The following is a description of a gene set: Human Gene Set: CARRILLOREIXACH_HEPATOBLASTOMA_VS_NORMAL_DN from publication Carrillo-Reixach J, Torrens L, Simon-Coma M, Royo L, Domingo-Sàbat M, Abril-Fornaguera J, Akers N, Sala M, Ragull S, Arnal M, Villalmanzo N, Cairo S, Villanueva A, Kappler R, Garrido M, Guerra L, Sábado C, Guillén G, Mallo M, Piñeyro D, Vázquez-Vitali M, Kuchuk O, Mateos ME, Ramírez G, Santamaría ML, Mozo Y, Soriano A, Grotzer M, Branchereau S, de Andoin NG, López-Ibor B, López-Almaraz R, Salinas JA, Torres B, Hernández F, Uriz JJ, Fabre M, Blanco J, Paris C, Bajčiová V, Laureys G, Masnou H, Clos A, Belendez C, Guettier C, Sumoy L, Planas R, Jordà M, Nonell L, Czauderna P, Morland B, Sia D, Losic B, Buendia MA, Sarrias MR, Llovet JM, Armengol C (PMID 32240714) Genes down-regulated in hepatoblastoma (HB) tumors as compared with non-tumor (NT) adjacent tissue. Background & Aims: Hepatoblastoma (HB) is a rare disease. Nevertheless, it is the predominant pediatric liver cancer, with limited therapeutic options for patients with aggressive tumors. Herein, we aimed to uncover the mechanisms of HB pathobiology and to identify new biomarkers and therapeutic targets in a move towards precision medicine for patients with advanced HB.<br/>Methods: We performed a comprehensive genomic, transcriptomic and epigenomic characterization of 159 clinically annotated samples from 113 patients with HB, using high-throughput technologies.<br/>Results: We discovered a widespread epigenetic footprint of HB that includes hyperediting of the tumor suppressor BLCAP concomitant with a genome-wide dysregulation of RNA editing and the overexpression of mainly non-coding genes of the oncogenic 14q32 DLK1-DIO3 locus. By unsupervised analysis, we identified 2 epigenomic clusters (Epi-CA, Epi-CB) with distinct degrees of DNA hypomethylation and CpG island hypermethylation that are associated with the C1/C2/C2B transcriptomic subtypes. Based on these findings, we defined the first molecular risk stratification of HB (MRS-HB), which encompasses 3 main prognostic categories and improves the current clinical risk stratification approach. The MRS-3 category (28%), defined by strong 14q32 locus expression and Epi-CB methylation features, was characterized by CTNNB1 and NFE2L2 mutations, a progenitor-like phenotype and clinical aggressiveness. Finally, we identified choline kinase alpha as a promising therapeutic target for intermediate and high-risk HBs, as its inhibition in HB cell lines and patient-derived xenografts strongly abrogated tumor growth.<br/>Conclusions: These findings provide a detailed insight into the molecular features of HB and could be used to improve current clinical stratification approaches and to develop treatments for patients with HB. species: Homo sapiens, and this is the list of marker genes: TIFA, CHP1, CMYA5, FNDC5, REPS2, ADCY10, ACOT13, VIPR1, FGF14-AS2, CNDP1, LSMEM1, CLEC4G, ISOC1, NFKBIB, NLRP9P1, NFIA, AQP7P1, CA2, ENO1P3, NUDT13, MT1JP, ARAP2, SDHD, MAP1LC3A, ID1 (NCBI Gene Id 96820), CYP2C8, TCP10L, MMUT, MACROD1, ETHE1, NDUFAF1, PIK3C2G, TAF7L, GBA3, LINC01093, HSBP1L1, APBB1IP, RND3, ZSWIM6, MT2A, SHBG (sex hormone binding globulin), TMEM192, TRIM35, TAT, SLC6A16, FAH, BMPER (NCBI Gene Id 168667), CDA, MUC3A, CD244, NAT8, LACTB2, GCSH, UPP1, CYP4F22, GFRA1, ACADL, SLC35C1, FCGR2B, MT1M, CHCHD10 (coiled-coil-helix-coiled-coil-helix domain containing 10), GCNT1P3, NUDT10, PLCXD2, TDRD15, MMAA, LINC00313, SMTNL1, AQP4, ZG16, NLGN4X, FGGY, CFAP68, SETP17, ATP13A4, NTN1, CLDN10, APOC3, CELSR1P1, AVPR1A, HAO2-IT1, AUTS2, ABCC3, SYT17, TPRG1-AS1, ITLN1, LGSN, NECAB2, CD14, GUCA2B, GCGR, KCND3, AKR1D1, SAA1, ZFYVE28, ZDHHC19, HSD17B8, MOGAT2, ENTPD8, SDS, ALDOB, GPR17, SLCO1B7, ECHDC2, TRPM8, CP, KCNH7, MSRA, TNXA, COL25A1, LYSMD2, SEC14L2 (NCBI Gene Id 85372), PEX11G, PXDC1, NFKBIZ, SLC31A1, AFF3, RTL4, KLKB1, FNIP2, UAP1, NTS, FAM83G, MTHFD2L, LIMS2, STEAP3, FOLH1B, GLYCTK, GLOD5 (NCBI Gene Id 392465), SPATA6L, ACOX2, DHRS1, CAMK2B, ENPP7, SDSL, CRHBP, GDA, ACAA2, RAB20, SYDE2, WDR72, OSGIN1, LRCOL1, TTLL2, PNPLA7, PFKFB1, LINGO4, OAF, FFAR2, ACY3, GCSHP5, C4orf33, ADSS1, TMEM176B, NPM1P29, RNF125, ALDH8A1, SEC14L4, ACOT4 (NCBI Gene Id 122970, acyl-CoA thioesterase 4), ISOC2, NFIL3, SERTAD1, SMCO4, LINC00605, MTND6P4, RCC2P7, CLTRN, NEBL, CRCP, ABCA6, L3MBTL4, CYP1A1, CAPZA3, CNTN3, RNFT1, FAM238A, ALDH6A1, AVPI1, CYP8B1, LRAT, ACAD11, PLA1A, RPS6KA6, HMCES, CR1L, ACOT12, RN7SKP296 (NCBI Gene Id 106481823), SULT1A1, PCA3, LIPG, MEIOB, SLC46A3, CYP21A2, BTD, C4A, PRG4, PWWP3B, KNDC1, HORMAD2, ABHD2, NXF3, DGCR6L, PRRG4, COLEC10, CLRN3, SMIM2-AS1, XRCC6P1, MCEE, PGLYRP2, TPD52L1, APBA1, MIR4686, RNU6-339P, C6, ACACB, UBALD1 (UBA like domain containing 1), MMACHC, ASS1, MROH2A, RBBP4P1, HS1BP3-IT1, GHR, CLYBL, RASSF7, HM13-AS1, CTPS1, MTATP8P1, PEMT, CYP4F2, ASL, LARP1B, SLC2A10, BLVRB, CXCL2, TRAM2-AS1, POLD4, PLAAT3, TMEM132D, RBM46 (RNA binding motif protein 46), RNU6-863P, ETS2, SCP2, XBP1, VNN1, RPS6P16, ACOT6, ARL14, SLC22A1 (solute carrier family 22 member 1), MAJIN, STEAP4, FCN2, MCRIP2, LPA, ZCCHC24, GSTA2, CXCR1, SFRP5, F11, NUDT7, ALAS1, SLC30A4, AQP7, PSD4, KYNU, RNU6-733P, ACADS, SERPINB8, GRAMD4, ARHGEF26, RPL17P11, PTH1R, SLC25A4, SH3RF1, CYP2B6, PMEL, TSLP, CTH, AGL, MT2P1, NBPF20, ENPEP, RASGEF1B, PZP, HTR2A-AS1, CRYBB3, TRPV4, C2, GCH1, REEP6, GSTA1, SLC5A7, MAPRE3 (microtubule associated protein RP/EB family member 3), MTARC2, IVD, OXT, CYP4F11, GYS2, CYP2A7 (cytochrome P450 family 2 subfamily A member 7), FETUB, HRG, RDH16, LINC01620, CYP2D6 (NCBI Gene Id 1569), SEC14L3, LRRC3, ECM1, MAFK, CPT2, NKIRAS1, HMGB1P8, FOLH1, IRF1, ANG, G0S2, CHRM5, MTND4P19, CYP2A7P1, C17orf67, ZMYND15, UGP2, PLAAT4, TPST1, TSC22D2, VIPR1-AS1, NOL4, SPTBN2, PAOX, PAPSS2, ABCC11, SPATA32, DDX19B, SAA4, MRPL41, CADM2, AGXT, LRRC55, MROH7, ETFRF1, NDRG2, CXCL14, GRIN2B, C11orf54, BCHE, FAAH, ZC3H12A, KRT16P2, GGACT, SLC38A4, NNMT, SERBP1P6, ELOVL6, GPR157, N4BP2L1 (NCBI Gene Id 90634), SLC28A1, UGT1A9, KCNJ3, CES1, SLC41A2 (solute carrier family 41 member 2), INHBE, SYBU, APOL1, KIF19, TMEM82, DMRTA1, HPD, SMPD1, CRPPA, CYP4V2, MCC, GLRX, GFOD1, DNAJB3, IL17RC, GRIA3, GOT2, GPR182, TM6SF2, TGM2, AZGP1, RPL21P23, PLIN4, HISLA, PCCA, CFHR3 (complement factor H related 3), CTBS, ASS1P9, C4orf19, CRP, A1BG, ESRRA, ANXA10, RTP3, KRT8P3, GOLT1A, ADRA1A, MAP10, KRT18P11, ACADM (NCBI Gene Id 51779), PEX11A, CCDC71L, PALS2 (protein associated with LIN7 2, MAGUK p55 family member), UGT2B10, ALDH7A1, IRF7, GASK1A, RFPL1, MT1E, CFTR, SAA2, TSKU, KCNK1, TJP2, IGFALS, TDO2, COX6A2 (NCBI Gene Id 1339), C14orf180, NHLRC1, CES2, CYP2D8P, LYRM1, USP43, ALKAL1, GLYATL1, NAAA, UGT1A8, SULT1A2, NIPAL1, ADAMTS13, HPS5, COL28A1, ITIH4, ASPG, TUBE1 (tubulin epsilon 1), PXMP2, SLC3A1, NR1I2, SYT10, KPNA7, TEX30, MPPED1, AGPAT2, ARHGEF5, AK3P5, PLAC8, PTGR1, ZNF684, AGXT2, RN7SL48P, TPMT, CXCL6, HSD17B6, RETREG1, PNRC1, SLPI, MAB21L2, KLHL2, ID2, GSTA7P, PALM3, ACSL1, CYP4Z1, RIC3, USP38, CYP26A1, CFP, TP53TG1 (TP53 target 1), DNALI1, ENDOG, ACTBP9, MIR3682, ROPN1B, FAM99A, C1RL, RNU7-124P, NUGGC, IL1RAP, TRIM55, ABCA13, SHFL, COL6A6, EPHX2, CFI, THEM5, TRPV6, RILP, HAAO, PHYH, MEI4, PNPO, PPIEL, ECHS1, SYT7, INHBC, FAM83A-AS1, LCAT, PLGLB2, RUNDC3B, PVALB, LPIN2, PINK1 (NCBI Gene Id 65018), FNDC4, FGF23, CDNF, PHETA1, SHB, GJC3, UGT1A7 (UDP glucuronosyltransferase family 1 member A7), PPL, NUDT12, GLS2, DIPK1A, HSD3BP2, TMEM26, IFITM10, UBE2FP1, CFHR4, SIRT5 (NCBI Gene Id 285813), PTER, GNPNAT1, GRHL1, HAO2, CHRNA10, YPEL2, MPC1, ADRB2, UGT2A1, RBMXL1, MACO1, CUX2, ESR1, DMGDH, CNTFR (ciliary neurotrophic factor receptor), CIMAP2, MOCS1, GCLC, HJV, ETFDH, DBH, MLYCD, ZNF503-AS1, FDX1, APOL6, MARCO, CCDC196, MBL2, KIAA1217, MT1DP, SLFNL1, ABLIM3, ABCG2, CCDC38, GCKR, FTCDNL1, PRSS8, ANGPTL4, NRBP2, OR10J6P, GBP7, IRF8, GBP1, IYD, GPR158, STARD5, SGK2, SLC25A18, ECHDC3, FMO3, FAM180A, NRBF2, ASNSP3, ATOH8, GAREM1, ALDH2, KATNAL2, HAO1, DIO1, SGMS2, AKR7A3, GCLM, THRSP, CREM, FAM50B, DENND2C, FGF14-IT1, C4A-AS1, QDPR, SLC9B2, CLEC1B, HOGA1, MAP2K3, TSPYL5, ECI1, BCL2L10, PRRG2, ANKRD24, DTX1, IDO2, FDPSP3, PON3, SUCLG2, SOCS2, GLT1D1, MUC6, XAF1, MIR378A, SMIM14, PPP1R1A, FAM149A, LNX2, PGM2, ENO3, SAR1B, AQP4-AS1, ACSM3, IL27, MTND4P12, ALDH1B1, CACNB2, PPARGC1B, NRG4, MAP7, TTR, LONRF3, CFHR5, ACAA1, GAPDHP14, HINT2, NHERF2, FAM9B, MTND2P12, STEAP3-AS1 (STEAP3 antisense RNA 1), GSTZ1, DNAJC25, ORM2, SERPING1, GBE1, AMDHD1 (amidohydrolase domain containing 1), MYOM2, ACOX1, TMEM171, HMGB1P27, TMEM53 (NCBI Gene Id 79639), CCPG1, KRT16P3, PSMD10P2, PRR22, AR, RPS4XP5, PON1, CCNG1P1, FUOM, PCCA-AS1, ERN1, RNASE4, HAND2-AS1 (NCBI Gene Id 79804), GOLGA6B, RN7SL344P, NKX3-1, GOT1, LURAP1L, LONRF2, MYO16, SLC20A1, SYT12, HP, TRIB1, TPPP2, HSD11B1, SLAIN1, CBR1, MBL1P, MGST1, DERA, UROC1, SERPINE3, ADH4, CATSPERG, COX6CP16, DHODH, CYP2B7P, PLIN5 (NCBI Gene Id 440503), DDAH1, APOL2, FGFR2, CHST4, PCK2, S1PR2, UGT2B7, C4orf36, DYNLT5, BCKDHB, AGAP1-IT1, CYP39A1, ACY1, RGN (regucalcin), RRAS2, SAMD5, CYP1A2, XDH, EIF4EBP3, PRG2, MIDEAS, RNU5A-6P, RHOB, RDH5 (NCBI Gene Id 81991), ITIH4-AS1, RTL5, SNIP1, KRT16P1, SARDH, BANF1P2, IL1RAPL2, PGM1, ALPL, TEX26, ABTB2 (ankyrin repeat and BTB domain containing 2), AIG1, NPTX2, LDHD, SDHB, PLGLB1, SLC25A47, CETP, CYB5A, OXNAD1, ATP13A3-DT, OCIAD2, TRIB3, LPAL2, NDUFAF4, BLNK, RNU6ATAC18P, APOA5, BTBD16, INSIG1, UBXN10, DSG1, PGRMC1, LINC01151, C11orf65, SOD1, MCCC1, MAOB, FAM83F, PROZ, RHOD, LINC00311, URGCP, OTC, NDUFV2P1, KRT18P34, DHRS3, ADH7, PLGLA, ZYG11A, CECR2, TSPAN1, RIDA, UGT2B15, STX1B, DPPA2P4, HNRNPA1P9, CDC37L1, MTHFS, TRIM21, PIGR, C8B, IGF1, TTC36, LRRC37A7P, SOCS2-AS1, SRD5A1, HAND2, TMEM92, MGLL, APOF, ADK, TMEM45A, PLEKHF1, CSRNP1, TLR3, LINC00885, UGT1A2P, CLEC4M, PSMB8, RNA5SP37, ACSM5, RCL1, PRAM1, PRKAG2, NIT2, DPYD-AS1, KDM8, CFL2, ZBTB43, RNA5SP46, SLC25A16, HGFAC, CHST7, PPP1R3B (NCBI Gene Id 79660), LBP, PI4K2B, SLCO1B3, C4B, ABHD5, CYP2A13, UGT1A4, HSD3B2, DHRS12, MTND1P14 (NCBI Gene Id 100873337), NDST3, PPARGC1A, TRIM15, GREM2, UGT1A6, AKR1C4, SIGIRR, ABCB11, AKR1C6P, INHBB, SPATA41, TRPC5, IL4R, CCDC158, IL1RN, ARL5B, RCAN1, LINC00857, CBR4, ATG2A, TMEM176A, CYP2C18, SERTM2, DUSP23, ARHGEF26-AS1, CPEB3, SDR42E1, WNT11, PIGV, ZCWPW1, C6orf141, GPR88, IL32, TST, SLC27A2, NQO2, DECR1, GNMT, GPLD1, DCXR, BDH2, CTNNA3 (NCBI Gene Id 50620), RAB17, SAXO4 (NCBI Gene Id 220004), IL1RL2, INPP1, MTND5P11, ZNF367, NMRK1, EPHA2, C11orf71, STAB2, DAO, AKR1C5P, GPT, RARRES2, PAMR1, SYTL4, ASPA, GFOD2, SLC7A2, LINC01018, BBOX1, USP30-AS1, KRT7, BCKDHA, CRADD, MYH4, NAT2 (N-acetyltransferase 2, NCBI Gene Id 10), BCO2, NR0B2, AKR7L, C3P1, PRSS53, INS-IGF2, HMGN5, P2RX3, MRPS36P4, KMO, RETSAT, ATF5, IFITM3, OGDHL, NKAPL, LINC00399, HPGD, MTHFD1 (NCBI Gene Id 4522), MOCOS, HHIP, RNU6-796P, C1R, PHYHD1, PRKAG2-AS1, SLC5A1, GDPGP1, MT1X, NRAP, GNAO1, COX6B1P4 (cytochrome c oxidase subunit 6B1 pseudogene 4), GSTO1, FCN3, RNU2-28P, LINC00365, COQ3, HSD17B13, TPRG1 (tumor protein p63 regulated 1), SKAP1, DPF3, ABHD14B, PLPP6, CYP2A6, RBP5, SPR, AQP3, PLIN2, DBH-AS1, LITATS1, GPAT3, OIT3, CES1P2, SLC4A4, DDT (NCBI Gene Id 91323), TMEM205, CES4A, HSD3B7, SLC25A45, ALDH5A1, RBM47, PROSER2-AS1, RNF152, SUCLG2P2, EXPH5, USP2, TBX15, MASP2, C1S, IL18R1, ELMO3, ACO1, CBLC, DPYS, HSD17B10, TBXA2R, C8G, EHHADH, COBL, PIPOX (NCBI Gene Id 51268), SLC10A1, KHK, SPATA1, DEFB1, RAB26, GPD1, C3, PIM3, ADH1C, AKR1A1, APOC4-APOC2, ZNRF2, MLPH, HSD17B14, GCDH, UQCRQ, ADAMTSL4-AS1, BMP10, RPL17P50, SLC43A3 (solute carrier family 43 member 3), MAP3K14-AS1, MYOM1, CYP3A4, ABCA9, SEMA6D, BACH2, CYP2G1P, NAMPT, PTGFR, ADRA1B, DHRS4, DCPS, CYP4A11, CYP2C19, SLC51A, EYS, SULT2A1, MRO, NPM1P25, NDUFA6-DT, NPAS1, IL15RA, IDNK, KIAA1671, GRHPR, FBXO8, TTPAL (NCBI Gene Id 79183), USP12, LRG1, SHMT1, IER2, MS4A4E, SLC16A2, RGS9, RND1, PDIA5, ASS1P1, TMT1B, C8A, SFTPD, MT1F, CAT, GRAMD1C, CHST9, ACBD4, CYP21A1P, SPTBN4, CYP11A1, H19, PIK3AP1, RNU6-570P, TENM1, MIR5581, DLG2, TMEM184A, GOLGA6A, AKAP7, TSTD1, ARK2C, SPRYD4, HAL, SLC45A3, COQ9, CYP3A43, CIMAP1B, GLRX2, EEIG1, TUSC1, SPATA2L, PRADC1, CAPN5, ZMYND12, TMEM220, PMCHL2, MT1G, SERPINB9, ADAMTSL4, HNRNPA1P22, IL13RA2, SLC27A5, CHRNE, GABRB3, AZGP1P2, TPT1P12, HABP2, SLC22A18, PCK1, RBKS, GLYAT, MIP, GNE, TTC39C, LYPD2, MIA2, LHPP, ASS1P11, SATB1, CHAC2, RGPD3, SLC66A2, CCND2P1, RGPD2, ANGPTL6 (NCBI Gene Id 83854), C9, GCHFR, CMBL, KLHL15, CBS, TENT5A, RBPMS2, FADS6, RAB5IF, SIAE, MACC1, PCCB, CALR4P, GLYATL3, LINC-PINT, ST3GAL6, F11-AS1, ASPDH, DNAH5, GJB3, AQP7P2, AADAT, FAM110C, HMGCL, AZGP1P1, FAM99B, NNT, ACTR3C, TPST2, HIGD1A, HADH, STIMATE, ROS1, AIFM1, STAP2 (signal transducing adaptor family member 2), HTATIP2, PHLDA1, ZCCHC2, LYVE1, SDC4P, MIR146B, VNN3P, FAM20A, ALDH7A1P1, NSUN6, GSTA5, RIPK4, LYSMD3, DEPDC7, SLC37A4, SLC22A10, RIPOR3, UPB1, FAHD2A, MAT1A, ATP5F1AP3 (ATP synthase F1 subunit alpha pseudogene 3), SPDYC, RSPO3, RAB27A, SORCS2, ABAT, F2RL1 (F2R like trypsin receptor 1), SLCO1A2, BCL3, NLRP6, RNLS (NCBI Gene Id 55328), SLC1A1, NR1I3, FCAMR, SCN9A, NOCT, DHTKD1, MAP3K14, TTC22, LRRC3-DT (NCBI Gene Id 100861510), LINC00240, SLC22A2, MSRB1 (methionine sulfoxide reductase B1), MOGAT1, PRR18, ETNPPL, SPAG1, PCDH9-AS2 (PCDH9 antisense RNA 2), ACMSD, CRYL1, FBP1, ST3GAL6-AS1, PLPP3, BMERB1, SDC4, HOMER2 (homer scaffold protein 2), CES3, PPIF, GRM8, MT1L, SLC25A20, FMO4 (NCBI Gene Id 2329), ADHFE1, SMUG1P1, SIGLEC11, ETFBKMT, PTS, TMPRSS2, MFAP3L, GABARAPL1, SQOR, LONP2, NRG1, HERC5, PTPN3, TMOD1, MFSD2A, FAM221A (NCBI Gene Id 340277), HIBADH, ZC2HC1C, CYP4A22, APOC1P1, A2MP1, TIGD2, TREH, UBE2L6, TNFSF14, ARID3C, TFR2, HAMP, FBXW11P1, NAV2, C21orf91, SCNN1A, F9, CRPP1, SOCS6, NUDT16L2P, SLC22A7, MT1CP (NCBI Gene Id 4491), ARRDC4, ARMH1, CPNE8, VKORC1, VXN, DUSP5, MBNL2, HK3, DIRAS3, GADD45G, ACAT1, OPLAH (5-oxoprolinase, ATP-hydrolysing), HPX, FAM151A, CITED4, FXYD1, MT1H, CRAT, COX7B, FITM1, CYP2C58P, ADI1 (NCBI Gene Id 55256), RASL11A, TAPBPL, RPL7P60, LINC00844, ANO5, SLC35D1, MANCR, OASL, MTCP1 (mature T cell proliferation 1), RNU1-47P, TERB2, LINC00659, SLITRK3, HAGH, RMDN2, ANKRD18DP, C4BPAP1, RPL3P6, KCTD14